The following is a description of a gene set: Human Gene Set: MIR5690 Genes predicted to be targets of miRBase v22 microRNA hsa-miR-5690 in miRDB v6.0 with MirTarget v4 prediction scores > 80 (high confidence targets). from publication Chen Y, Wang X (PMID 31504780) species: Homo sapiens, and this is the list of marker genes: TAF5, GFRA4, SEMA4G, SV2A, FCHO2, TEAD1, BPNT2, UBE2J1, NEXN, SLITRK4, RBM27, GPR158, ANXA1, GFRA1 (NCBI Gene Id 2674), EIF2S3, DVL2, SMC2, PCSK1, ZNF468, PSD3, ZNF483, HMGCR, MAGIX, PDPK1, NOVA1, SNAP25, RBMS1, USP6NL, NXPH1, RIN2, DOK6, USP6, USP37, CCND2, RLIM, LIFR, EML6, IRAK1BP1, OTUD4, HMGB2, SDC2, ZNF800, MRPS35, TMEM43, CNTNAP2, CFL2, RBM22, PPDPFL, TFG, RASEF, KIR3DL1, APAF1, USP32, CTPS2, RBFOX2, FRYL, PACS2, TFR2, SELENOS, ZHX1, EXOC8, RSBN1, EIF4ENIF1, PITPNB, MYLK4, RHOT1, NCAM1, ZNF543, YWHAB, GEMIN2, HTR7, ANP32B, PCDH17, YLPM1, WWTR1, UBE2E3, MCOLN3, RBM15 (RNA binding motif protein 15), TRIM23, CLDN11, ZNF528, NEFH, TIMP3, FBXL20, HSD3B1, STK38L, SLC16A10, TCF7L1, MDM4, BTBD10, TTC39C, MPRIP, B4GALT5, SYNRG, CYP4F11, SNRNP48, BRINP3, LRPAP1, ZNF652, NOTCH3, UGT8, VPS13D, ATP9A, SHANK2, GPR137B, OSBPL3, BCHE, CTCF, MEOX2, MTSS1, ETS1, ISCA1, PLAGL2, SYDE2, DYNC1I1, HSPB8 (heat shock protein family B (small) member 8), KIAA1549L, WNT3